Given this list of marker genes Fam184a, Fcer1g, Epop, Fam163b, Brpf3, Lrrc15, Casp9, Fancc, Adgrg5, Dbx1, Ubr4, here is a description of the gene set: Mouse Gene Set: MIR_802_3P Genes predicted to be targets of miRBase v22 microRNA mmu_miR_802_3p in miRDB v6.0 with MirTarget v4 prediction scores > 80 (high confidence targets). from publication Chen Y, Wang X (PMID 31504780) studied in species Mus musculus